The following is a description of a gene set: from publication Zak DE, Andersen-Nissen E, Peterson ER, Sato A, Hamilton MK, Borgerding J, Krishnamurty AT, Chang JT, Adams DJ, Hensley TR, Salter AI, Morgan CA, Duerr AC, De Rosa SC, Aderem A, McElrath MJ (PMID 23151505) To better understand how innate immune responses to vaccination can lead to lasting protective immunity, we used a systems approach to define immune signatures in humans over 1 wk following MRKAd5/HIV vaccination that predicted subsequent HIV-specific T-cell responses. Within 24 h, striking increases in peripheral blood mononuclear cell gene expression associated with inflammation, IFN response, and myeloid cell trafficking occurred, and lymphocyte-specific transcripts decreased. These alterations were corroborated by marked serum inflammatory cytokine elevations and egress of circulating lymphocytes. Responses of vaccinees with preexisting adenovirus serotype 5 (Ad5) neutralizing antibodies were strongly attenuated, suggesting that enhanced HIV acquisition in Ad5-seropositive subgroups in the Step Study may relate to the lack of appropriate innate activation rather than to increased systemic immune activation. Importantly, patterns of chemoattractant cytokine responses at 24 h and alterations in 209 peripheral blood mononuclear cell transcripts at 72 h were predictive of subsequent induction and magnitude of HIV-specific CD8(+) T-cell responses. This systems approach provides a framework to compare innate responses induced by vectors, as shown here by contrasting the more rapid, robust response to MRKAd5/HIV with that to yellow fever vaccine. When applied iteratively, the findings may permit selection of HIV vaccine candidates eliciting innate immune response profiles more likely to drive HIV protective immunity. species: Homo sapiens Human Gene Set: ZAK_PBMC_MRKAD5_HIV_1_GAG_POL_NEF_AGE_20_50YO_CORRELATED_WITH_CD8_T_CELL_RESPONSE_3DY_POSITIVE Genes positively correlated with CD8+ T-cell response in peripheral blood mononuclear cell in adults (20-50) after exposure to MRKAd5 HIV-1 gag/pol/nef, time point 3D, and this is the list of marker genes: CCDC186, KIF2A, ZBTB44, DENND4C, ANKRD10-IT1, LCOR, DHFR, SH2D1B, GOLGA4, ATOSA, MAP4K5, SNRNP27, PTPN22, ZNF134 (zinc finger protein 134), SLC25A40, COP1, HNRNPA3, GNG11, RAMAC, ARB2A, MIER3, CTDSPL2, ZNF131, MGAT4A, WASHC2C, ESF1, PIGK, FBXO11, ZNF765, GARS1-DT, TRGJP1, ZNHIT6, ZNF654, SBDS, GOLM2, TRPM7, HOOK3, CEBPZOS, ZNF280D, ZNF761, KIN, PCNP, LMAN1, HAUS6, SINHCAF, RASA2, ZNF431, THAP9-AS1, SLC16A6, TRAJ40, TRGC2, KTN1 (NCBI Gene Id 8109), HAUS3, GCC2, PCGF5, GTF2H3 (general transcription factor IIH subunit 3), ZNF518A, TRAV13-1, KDM3A, ZNF484, CLEC2D, ATRX, ZNF510, MIS12, ZNF507, FYTTD1, PIK3R1, SNORD28, ZNF486, ARHGAP12, ARID4A, CCNT1, SLC30A9, PLEKHA1, LRRC37B, ESCO1 (NCBI Gene Id 114799), KIR2DL1, PRKAR2B, ZNF845, ANKRD12, SMURF2, CDK8, PDGFD, ZNF721